Given this list of marker genes ERRFI1, GK, TRAPPC11, TRIM2, KCNJ16, ATN1, DRD3, RGL1, CYCS (NCBI Gene Id 54205), PAM, TMEM8B, RWDD4, CTRL, ST8SIA5, SEMA6D, OTX2, ESRP2, SYT13, CBX4 (NCBI Gene Id 8535), MANF, NEFM, CXXC4, H1-1, HRH3, ARPC5, BAZ2A, ID2, CHD6, SYT7, RASSF8, ARMCX6, EIF4H, MT3, VGF, HDAC3, ATP5F1B, STIM1, SEPTIN4, KRT10, ATP2A2, SOCS5, ANO4, ELAVL2, PTPA, CHST8, ALKBH6, H2AZ1, SLC49A4, SLC38A2, THRA, SNCB, GABRA3, KCNAB3, MLLT6, PANK3, MCAM, IGSF3, CS, PRKACA, VAMP2, ZNF655, NPTX2, SNTA1, PHYHIPL, SCN2B, HOXD11, PPTC7, FLJ40288, NABP2, CITED2, TNKS1BP1, CNBD1, ZIC3, ANKRD42, NDUFA12, AMY2A, SYNPO2L, CLCNKA, RELL2, SUMO4, ESM1 (NCBI Gene Id 11082), SARM1, EMX2, ALDOA, AFP, HSPBAP1, FHL2, HMGCS1, GPI, PRKCE, CRAT, LDHB, ADAM11, AAK1, GAS6, PRKAG1, ARAP2, YWHAG, here is a description of the gene set: Comprehensive identification of all functional elements encoded in the human genome is a fundamental need in biomedical research. Here, we present a comparative analysis of the human, mouse, rat and dog genomes to create a systematic catalogue of common regulatory motifs in promoters and 3' untranslated regions (3' UTRs). The promoter analysis yields 174 candidate motifs, including most previously known transcription-factor binding sites and 105 new motifs. The 3'-UTR analysis yields 106 motifs likely to be involved in post-transcriptional regulation. Nearly one-half are associated with microRNAs (miRNAs), leading to the discovery of many new miRNA genes and their likely target genes. Our results suggest that previous estimates of the number of human miRNA genes were low, and that miRNAs regulate at least 20% of human genes. The overall results provide a systematic view of gene regulation in the human, which will be refined as additional mammalian genomes become available. Genes having at least one occurrence of the highly conserved motif M109 YGTCCTTGR in the regions spanning 4 kb centered on their transcription starting sites. The motif does not match any known transcription factor binding site. studied in species Homo sapiens from publication Xie X, Lu J, Kulbokas EJ, Golub TR, Mootha V, Lindblad-Toh K, Lander ES, Kellis M (PMID 15735639) Human Gene Set: YGTCCTTGR_UNKNOWN